The following is a description of a gene set: species: Homo sapiens Reactome Pathway: Scavenging by Class A Receptors Class A scavenger receptors contain an intracellular domain, a transmembrane region, a coiled-coil domain, a collagenous domain, and the SR cysteine-rich domain. The coiled coil domains interact to form trimers. The collagenous domain and/or the SR cysteine-rich domain bind ligands and determine the specificity of the receptor. part of: Binding and Uptake of Ligands by Scavenger Receptors, and this is the list of marker genes: APOA1, SCARA5, COL4A2, APOB, FTL, COL3A1, COL4A1, CALR (NCBI Gene Id 811), MSR1, MASP1, COLEC12, MARCO, APOE, FTH1, HSP90B1 (NCBI Gene Id 7184), SCGB3A2, COLEC11, COL1A1, COL1A2